Given this list of marker genes Tpm1, Mtpn, Ssh1, Capza2, Svil, Arpc2, Capza3, Twf2, Rdx, Kank2, Twf1, Avil, Eps8, Arfgef1, Ssh2, Mkks, Tmod4 (NCBI Gene Id 50874), Kank3, Tlr2, Sptb (NCBI Gene Id 383567), Flii, Evl, Capn1, Lmod2, Capg, Vill, Capzb (capping actin protein of muscle Z-line subunit beta), Tmsb15l, Tmod1, Tmod2, Gsn, Add3, Cfl1, Ssh3, Vil1, Capza1b, Tmsb4x, Tmod3, Bbs4, Cyrib, Pecam1, Capza1, Kank4, Add1, Dbnl, Sptan1, Lmod3, Add2, Pfn2, Carmil1, Lmod1, Myadm, Kank1, Cracd (NCBI Gene Id 75147), Scin, Slit2, Dmtn, Tmsb15b2, Fhod3, Spta1, Prkcd, Pfn1, Sptbn1, Myh9, Carmil2, Hip1r, here is a description of the gene set: Any process that stops, prevents, or reduces the frequency, rate or extent of actin polymerization. Mouse Gene Set: GOBP_NEGATIVE_REGULATION_OF_ACTIN_FILAMENT_POLYMERIZATION studied in species Mus musculus